Given this list of marker genes Cemip, Gpr107, Snap91, Picalm, Cltb, Tom1, Lmbrd1, Clta (NCBI Gene Id 230110), Plk2, Lrp1, Dnajc6, here is a description of the gene set: Binding to a clathrin heavy chain. Mouse Gene Set: GOMF_CLATHRIN_HEAVY_CHAIN_BINDING species: Mus musculus